Given this list of marker genes Gh, Kcna1, Ascl1, Trp53, Drd2, Cx3cr1, Bex1, Cip2a, Disc1, Tafa1, Mapk8, Zfp335, Wnt3a, Foxg1, Vegfc (vascular endothelial growth factor C), Lrp6, Nbn, Kctd11, Fgfr2 (NCBI Gene Id 20946), Cdon, Lef1, Ptn, Tgfb1, Notch1, Otp, Nf1, Pafah1b1, Hif1a, Skor2, Acsl6, Neurod4, Sall1, Fgfr3, Kdm1a, Kifap3, Bdnf, Vax1, Lhx5, Eml1, Sox2, Rab10, Gli3, Fgf13, Numb, Racgap1, Daglb, Six3, Id4, Lrrk2, Fgf2, Dock7, Sox10, Shh, Nde1, Tead3, Akna, Frs2, Plxnb2, Dmrta2, Ctf2, Nfix, Sox5, Ctnna1, Aspm, Itgb1, Ctnnb1, Dct, Wdr62, Pax6, Fgfr1, Smo, Vegfa, Cd24a, Btg2, Hhip, Smarcd3, Dagla, Numbl, Cx3cl1, Fzd3, Zzef1, Arhgef2, Nr2e1, Prl2c2, Vsx2, Fzd9, Prox1, Gata2, here is a description of the gene set: The expansion of a neuroblast population by cell division. A neuroblast is any cell that will divide and give rise to a neuron. Mouse Gene Set: GOBP_NEUROBLAST_PROLIFERATION studied in species Mus musculus